The following is a description of a gene set: from publication Wong AW, Brickey WJ, Taxman DJ, van Deventer HW, Reed W, Gao JX, Zheng P, Liu Y, Li P, Blum JS, McKinnon KP, Ting JP (PMID 12910265) Human Gene Set: GSE557_WT_VS_I_AB_KO_DC_UP Genes up-regulated in dendritic cells: wildtype versus I ab-/- mice. Triplicates preparations of RNA from day 10 DC's. Experiment is described in Wong et al 2003 Nat. Immunol. species: Homo sapiens, and this is the list of marker genes: TNFAIP8L2, IFNAR1, METTL1, ARAF, ACSS1, SNX33, CD151, MMP24, TEX2, ABHD17B, UBR1, PAN2, ELAC1, LRRC61 (NCBI Gene Id 65999), FLAD1, GTPBP6, BACE1 (beta-secretase 1), C3orf33, OVCA2, CAPN5, FCSK, IP6K1, SLC36A2, TRIM7, TRMT1, TMC4, TOR4A (torsin family 4 member A), GLO1, LPCAT1, EHBP1, BIVM (NCBI Gene Id 54841), TOM1L2, VPS37B, ZFP14, OGA, NFS1, MAP7, CNPY3, GTPBP2, PREB, TSPAN2, PDLIM5, HLA-DOA, HDDC2, CACNB4, ERI3, UNC50, FAM120AOS, NOXRED1, KYNU, ARHGAP4, MCCC1, ZNF808, SLC35C2, MANBA, GANC, ZBTB18, FAM193B, ZFP28, GOLM1, PRKAB2, TRIM24 (NCBI Gene Id 8805), ADORA3, RAB33B, ITPK1, STX16, AMER1, MCL1, ST6GALNAC3, AS3MT, ZKSCAN8 (zinc finger with KRAB and SCAN domains 8), LDLRAP1, TMEM147, NCDN, ORAI3, NID1, GOLGA5, HSH2D, AP3M2, TRAF1, FAM111A, SLC35B3, GRINA, RWDD4, SLC35A1, SPTBN1, OAS2, EARS2 (glutamyl-tRNA synthetase 2, mitochondrial), GNE, PDLIM2, MOSPD3, PATJ, NDFIP1, NRDE2, CLIC4, TTC14, CLK2, WDR11 (NCBI Gene Id 79207), MTMR4, YOD1, TSPAN15, ARL14EP (NCBI Gene Id 120534), TRIP11, EXTL2, STARD10, DUSP12, MOSMO, KLHL17, AKAP7, DHX33, TEP1, GPR183, FBXL4, DCXR, CRELD1, CFAP96, ETV3, CLCN5, ABCD4, KLHL22, CRACDL, LAMTOR3, DENND6B, SHARPIN, ASAP2, AP5Z1, PTPN18, PPFIBP2, RAB12, SBSN, ADI1 (NCBI Gene Id 55256), AZI2, POU6F1, PAXX, SLC43A2, TSHB, SSR4, WDR13, NUP160, INPP5F, ABHD2, ENSG00000267882, PTGER4, SNX2, TASOR2, ANKRA2, MTERF3, IFFO2, PARP2, CDC42SE1, CDK10, BTK, GPR137, STAT6, TNFRSF13B, PUS3, CCDC28A, CCDC62, REEP5, CCNJ, CCR5, RGP1 (RGP1 homolog, RAB6A GEF complex partner 1), TBK1, TSPO, FAM149A, NEB, BLOC1S2, RELCH, SLC20A2, FBXO38, DENND1C, DOCK2, PARD6G, MIA3, PFDN5, ANGEL1, ICE2, COMTD1, TMTC2, SEPTIN9, ARID4B, ACAA1, CERS2, PXN, CYLD, DOK3, CDIP1, PTPN6, EPS15, RNF123, ARHGAP45, KLF12, CCDC125, AFP, ZYG11B, TCEA2, SPAG9, GML, PTPRE, TG